The following is a description of a gene set: Catalysis of the reaction: an acyl-CoA + H2O = a carboxylate + CoA + H+. species: Homo sapiens Human Gene Set: GOMF_ACYL_COA_HYDROLASE_ACTIVITY, and this is the list of marker genes: ACOT7, PPT1, ABCD3, ABCD1, ACOT1, ACAA2, ACOT11, ABCD2, ACOT6, ENSG00000293349, ACOT9, BAAT, CLN5, ACOT2, HIBCH, DESI1, THEM4, MBLAC2, PLA2G6, ACOT12, ACOT4, ACOT8, DESI2, ACOT13, HADHA, PPT2, THEM5, ACSBG2